The following is a description of a gene set: studied in species Mus musculus FGFR2c ligand binding and activation Mouse Gene Set: REACTOME_FGFR2C_LIGAND_BINDING_AND_ACTIVATION, and this is the list of marker genes: Fgf18, Fgf20, Fgf1 (fibroblast growth factor 1), Fgf6, Fgf2, Fgf4, Fgf16, Fgf5, Fgf9 (NCBI Gene Id 252883), Fgf23, Fgf17, Fgf8